Given this list of marker genes Zbtb24, Dtx1, Extl2, Tcf20, Mgat5, Pygo1 (pygopus 1, NCBI Gene Id 72135), Slfn8, Zfp93, Znrf3, Pex2 (NCBI Gene Id 52109), Agap3, Zfp24, Cyp2c55, Smyd3, Zmynd8, Cyp2b9, Rasal1, Rarg, Prdm16, Rest, Phf2, Dbh, Zfp146, Wdfy2, Tet1, Npepl1, Zfp14, Tshz3 (NCBI Gene Id 338507), Kat6b, Dpys, Ang6, Galnt4, Adap2, Acap1, Rbm4, Zup1, Scd1, S100a3, Semg1, Tk1, Zfp687, Dmd (dystrophin, muscular dystrophy), Nudt16, Rnf185, Neil2, Rpl37a, Zcwpw2, Zfp706, Usp19, Git1, Scd3, Egr4, Cyp2u1, Zfand4, Trim67, Zglp1, Tdrd1, Enpep, Suz12, Cbll1, Klf7, Rnf14, Cpe, Zkscan14, Aire, Ace, Tesl2, Kmt2b, Rbsn, Car7, Litaf, Esr1, Atf2, Tcea1, Prkce, Tnip2, Nr5a1, Zmym5, Cgrrf1, Alox8, Rtp4, Cyp2c37, Mta2 (NCBI Gene Id 23942), Zfp628, Pim1, Rnf122, Trim45, Cpn1 (NCBI Gene Id 93721), Phf7, Trim28, Prkci, Scd4, Zeb2, Ikzf3, Smyd1, Yod1, Zfp668, Rad18, Esr2, Nr3c1, Mgrn1, Kdm4b, Unc13c, Ch25h, Alox5, Trhde, Zscan21, Dpp3, Dgka, Rbm20, Hdac4, Thap4, Ethe1, Prm2, Ankmy1, Galnt3, Loxl4, Nr5a2, Gatad1, Upf1, Mre11a, Smpdl3a, Ing2, Rnf8, Zfp932, Trim66, Kmt2e, Car2, Brpf3, Adnp2, Nr2e3, Nr6a1, Sod1, Trim54, Sprtn, Ccnb1ip1, Tax1bp1, Sec23a, Rbbp6, Mib2, Shprh (SNF2 histone linker PHD RING helicase), Astl, Hephl1, Wdr59 (WD repeat domain 59), Gstm1, Gtf2e1 (general transcription factor II E, polypeptide 1 (alpha subunit)), Ebf3, Rnf13, Polr2k, Rnf215, Mid2, Trim26, Timp3, Mgat5b, Prkcz, Rnf144b, Nr1h2, Zbtb6, Shank3, Xpa, Phf11a, Cyp1b1, Hmgcl, Hic2, Ing1, Otud7a, Commd1, Cbl, Cblb, Nbr1, Pepd, Mmp17, Trim65, Fgd4, Epas1 (endothelial PAS domain protein 1), Zfat, Pglyrp1, Kcmf1, Prnd, Fthl17a, Ppm1k, Prkch, Zmym2, S100a5, Adamts1, Toe1, Dcst1, Papola, Car9, Cyp2a4, Zfp322a, Cdip1, S100a4, Arg1, Srek1ip1, Kat8, Nr3c2, Ptms, Mllt10, Flywch1, Mmp11, Zfp697, Morc2a, Cyp1a1, Nob1 (NCBI Gene Id 67619), Zfp418, Zcchc2, Dclre1a, Osr1, Hltf, Mlph, Zfp689 (NCBI Gene Id 71131), Gli3, Mmp15, Nr2e1, Agmo (NCBI Gene Id 319660), Ptch1, Polr2i, Cyp2c39, Idi1-ps1, Zfp28, Fntb, Hpd, Ppm1n, Phc3, Acp5, Gata2, Glis3 (GLIS family zinc finger 3), Zfp184, Kdm5d, Zfp536, Polr1a, Marchf8, Zfp296, Pogz, Zmiz2, Tab3, Atp2c1, Hdac6, Dtx4, Aox4, Alox12b, Irf2bp2, Car4, Car14, Zfand1, Flg2, Zfp511, Sharpin, Zswim8, Obi1, Bbox1, Zbbx, Fn1, Mgat1, Zfp1, Moxd1, Vav2, Alpi, Rnf166, Xdh, Zfp608, Siva1, Maz (NCBI Gene Id 17188), Zfp335, Anapc11, Polh, Zfp143, Cdo1, Dtna, Zfp653, Esco2, Rbak, Loxl2, Hr, Mdm4, Tiparp, Snrnp48, Zfp326, Rock2, Pnma3, Tshz1, Zfp385c, Prkd2, Zmynd15, Prdm14, Parp12, Rtl4, Polr1h, Cyp2b19, Eprs1, Zfp3, Tut7, Adcy2 (NCBI Gene Id 238696), Gpx3, Gpatch8, Zfp35, Plekhm3, Cuta, Marchf5, Ash1l, Nr4a3, Zc3h6, Zfp592, Thap11 (NCBI Gene Id 76841), Smyd5, Wrnip1, Car1, Fthl17f, Zfp488, Zscan4f, Egr2, Casz1, Tnfaip3, Car11, Fhit, Smyd4, Capn15, Rnf148, Ciapin1, Akp3, Nr2c1, Glis2, Tns2 (NCBI Gene Id 209039), Rnf43, Rnf10, Sp4, Ing4, Nr2f2, Dtx3, Vav1, Chd4, Sh3rf1, Cnot4, Vps41, Peg3, Prkn, Ide, Sirt3, Hnf4g, Phf1, Rc3h1, Unc13a, Ar, Thap1, Car3, Adnp, Zfpl1, Cxxc5, Tab2, Atrx, L3mbtl4, Dtx3l, Zfp639, Mynn, Trim10, Rnpep, Pcgf6, Rims1, Zfp451, Zscan20, Polr3b, Zbtb7b, Bmx, Fan1, Pcgf1, Pex10, Champ1, Zfp580, Rere, Timp2, Klf17, Svs3b, Cad, Baz2a, Mefv, Rnasel, Esrrg (NCBI Gene Id 26381), Hivep2, Zfp54, Brf1, Zfp654, Zfand5, Zfp518b, Coa6 (cytochrome c oxidase assembly factor 6), Chordc1, Tars1, Zc3h14, Prickle3, Svs3a, Rnf6, Zfp280d, Dgkb, Prickle1, Arap1, Cyp27a1, Lnpk, Trps1, Pias3, Cyp3a25, Rnf19a, Slx4, Dhx57, Zfp579, Rnf103 (NCBI Gene Id 232080), Cyp21a1, Nudt3, Trim43c (tripartite motif-containing 43C), F5, Zfyve19, Nos1, Chn2, Ski, Mkrn2, Rtp3, Cyp3a11, Brf2, Cyp2d26, Rorc, Zfp830, Rnf182, Cyp2c29, Sall1, Adh6b, Pglyrp3, Zfp90, Zc3h3, Cyp2s1 (cytochrome P450, family 2, subfamily s, polypeptide 1), S100a7a, Rffl, Mib1, Fthl17b, Cyp2c40, Zgpat, Zbed6, Dpyd, Trim13, Trim32, Zc3hav1, Hic1, Mmp7, Zmym3, Plod1, Lhx5, E4f1, Zfp354c, Smpd1, Qpct, Zfp750, Heph, Mnat1, Mt2, Zfp276, Calcoco1, Nup42, Fto, Ppara, Grin2b, Zbed4, Rps27a, Th, Aopep, Runx1t1, Bcl6, L3mbtl2, Matr3, Gpc1, Fus, Rtn4ip1, Siah1a, Ppp1ca, Prr3, Supt4b, Siah2, Zfand6, Sumf1, Itk, Gfi1, Zfy1, Abcc8, Zc3h13, Lnx1, Zswim5, Aplp1, Msmo1, Dhx58, Zfp330, Zfp277, Zfp821, Baz1b, Triml1, Fgd2, Wdr24, Plekhm1, Zfp128, Dnaja3, Sirt5, Rbm5, Kdm5a, Tns1, Slc4a8, Zgrf1, Trim16, Ppef1, Zfp445, Egr3, Rnft1, Trmt44, Dzank1, Mme (membrane metallo endopeptidase), Cpa3, Dnaja2 (DnaJ heat shock protein family (Hsp40) member A2), Lonrf3 (NCBI Gene Id 74365), Zfp638, Hinfp, Zfp41, Gda, Mgat2, Hdac10, Nfu1, Rspry1, Cyp4f18, Plscr3, Galnt1, Akap8l, Hba-x, Zfp292, Rxra, Prdm8, Adamts8, S100b, Calr, Kdm2b, Gcm1, B4galt1, Trim46, Adh4, Lin28a, Samhd1, Aoc3, Bcl11a, Prdm1, Sall2, Cpz, Asap3, Traf1, Nqo2, Slu7, Sec24a, Zhx2, Mbd1 (NCBI Gene Id 17190), Cyp2c23, Fezf1, Zfpm1, Xpnpep3, Cyp26c1, Rpl37, Bspry, Dgkz (diacylglycerol kinase zeta), Pglyrp2, Patz1, Zfp37, Mecom, Rnf223, Cyp4a10, Tdp2, Cyp2f2, Fthl17e, Zfp473, Zcrb1, Sec24d, Racgap1, Zfr, Zfp683, Zmat5, Aox1, Thap2, Supt4a, Mss51, Zfp800, Gyg1, Znfx1, L3mbtl1, Ighmbp2, Fgd6, Ctcf, Tut4 (terminal uridylyl transferase 4), Fthl17c, Phf21a, Marchf9, Zfp329, Qtrt2, Usp49, Cbfa2t2, Bsn, Rnf20, Rnf135, Zfpm2, Zswim4, Smap2, Aoc1, Apobec1, Agbl4, Zbtb8a, Dpep1, Zfp462, Zfhx4, Zswim7 (NCBI Gene Id 69747), Cyp2a5, Zkscan5, Agbl2, Rnf121, Sec24b, Ankzf1, Trmt1, Ang4, Rp9, Polr1b, Zcchc3, Zfp27, Zfp239 (NCBI Gene Id 22685), Ebf2, Sco2, Nr4a2, Osr2, Fgd5, Gch1, Rreb1 (NCBI Gene Id 68750), Hgs, Zfp879 (NCBI Gene Id 214779), Shh, Zfy2, Mid1, Rnf146, Cox11, Zfp287, Rnf128 (ring finger protein 128), Trp53, Zfp74, Rev3l, Zfp768, Dctd, Zfp710, Usp16, Klf5, Fa2h, Zfp12, Tssk3, Zfp346, Rnf212b, Ftmt, Fthl17d, Ogfod1, B4galt7, Trim34a, Dnmt3a, Zfp426, Lnx2, Arhgap29, Ppm1b, Lcn2, Rnf111, Def8, Sp8, Zfp775, Myt1l, Abo, Dgkg, Alox15, Sytl5, Cdadc1 (cytidine and dCMP deaminase domain containing 1), Zfp366, Trim14 (tripartite motif-containing 14), Trim56, Recql4, Rnf11, Cpa4, Cyp2c50, Zcchc18 (zinc finger, CCHC domain containing 18), Zfp646, Exd2, Ftl1, Ppef2, Rag1, Agfg2 (NCBI Gene Id 320059), Zhx1, Mmp2, Chfr, Mmp19, A430033K04Rik, Zswim3, Zfyve26, Plod2, Dnaja4, Lancl1, Sncb, Trim40, Phf19, Rnf7, Idi1 (isopentenyl-diphosphate delta isomerase), Vat1, Aicda, Or4e2, Sp9, Mul1, Zfp316, Alox12e (arachidonate lipoxygenase, epidermal), Adi1, Ube3a, Zfp280c, Zpr1, Kdm1b, Rbm10, Hamp, Agap1 (ArfGAP with GTPase domain, ankyrin repeat and PH domain 1), Cpa6, Dtnb, Asap1, Kmt2d, Mkrn3, Adamts15, Vav3 (vav 3 oncogene), U2af1, Chd5, Sntn, Zfp385b, Mmp20, Trim6, Arfgap3, Dpf1, Cdc42bpa, Trim41, Tada2a, Zfp786, Zc3hc1, Prdm4, Rnf183, Gata3, Cyp4a14, Zfp598, Haao, Zfp422, Rnf126, Trim60, Scnm1, Ikzf2, Atp7b, Prkcb, Rarb, Pias4, Gtf2h2, Prdm10, Zranb2, Smpdl3b, Zbtb7a, Trim59, Zfp513, Hrnr, Akap8, Stac, Mmp12 (NCBI Gene Id 17381), Tcea3, Agbl5, Zbtb5, Ifih1, Rnf216, Taf1b (NCBI Gene Id 78429), Zkscan3, Ece1, Birc7, Hhip (NCBI Gene Id 56864), Klf3, Cyp4v3, Zfp652, Sap30l, Bhmt1b, Prickle2, Git2, Enpp1, Rtp1, Rnf167, Vdr, Jade2, Zfp526, Zfp106, Prim1, Trim38, Irf2bp1, Cyp26a1 (NCBI Gene Id 13082), Cyp7b1, Bard1, Trit1, Zfp82, Mmp3, Trim42, Zbtb43, Zbtb46, Rbm22, Marchf3, Txnrd1, Zfp428, Arfgap1, Ebf4, Klf9, Nr4a1 (nuclear receptor subfamily 4, group A, member 1), Zik1, Polr2l (polymerase (RNA) II (DNA directed) polypeptide L), Arfgap2, Trim3, Sap30, Adprm (NCBI Gene Id 66358), Usp20, Pck1, Zranb1, Znrf4, Bhmt2, Lox, Usp45, Uimc1, Usp22, Trim36, Esrrb, Car15, Rnf25, Zic2, Rnf141, Cyp2d9, Ccs (NCBI Gene Id 12460), Scrt1, Fam20c, Rpa1, Pgr, Klf14, Zfp39, Aplp2, Cdipt, Klf10, Syvn1, Car13 (NCBI Gene Id 71934), Xpnpep1, Klf1, Birc5, Adam8, Bmi1, Rxrb, Zrsr2, Traf4, Neurl1a, U2af1l4, Ado, Trim43b (NCBI Gene Id 97529), Vat1l, Tesl1, Neurl3, Zfp770 (NCBI Gene Id 228491), Ing3, Sall4, Znrf2, Pola1, Wdfy3, Mtf2, Ing5, Mta1, Zfp827, Trip12, Mmp21, Eri2, Zfp664, G2e3, Acer3, Rph3al, Cyp11b2, Fyco1, Rnf224, Tbxas1, Sytl3, Thrb (NCBI Gene Id 21834), Ankfy1, Zfp672, Lap3, Prkd1, Trerf1, Thap12, Ada, Sod2, Sp1, Zfp91, Cyp2w1, Zfp414, Rufy4, Zfp523, Zc2hc1c, Cyp2d10, Ankmy2, Acmsd, Zcchc4, Trim30a (tripartite motif-containing 30A), Adamts2 (NCBI Gene Id 327918), Top3a, Btk, Timp4, Tut1, Trim71, Pole, Tes, Cyp2b10, Zfp704, Tet3, Pter, Sec23b, Prkcg, S100a6, Klf16, Unkl, Rnf26, Zbtb3, Lvrn, Unk, Crebbp, Rnf144a, Pitrm1, Znhit1, Ppm1a, Rnf115, Znrf1, Zcchc17, Cyp2c70, Dnmt1, Cpsf4, Helz2, Zfp110, Jmjd1c, Itgb1bp2, Smyd2, Zranb3, Jade1, Mt3, Il1a, Rc3h2, Zfp369, Ints12, Gmip, Enpp7, Ikzf4, Ovol3, Bmp1, Lims1, Glo1, Car5a, Zfp711, Fnta, Fbxo43, Zmat3, Zfp521, Ppard, Phf20l1, Cyp2r1, Trim39, Dido1, Prnp, Pcgf5, Fhl2, Zfp13, Aoc1l3, Pja1, Chn1, Rasa2, Gata5, Raf1, Npepps, Zfp551, Gfi1b, Nek4, Traf3, Agtpbp1 (ATP/GTP binding protein 1), Riox1 (ribosomal oxygenase 1), Ptgr3, Mbnl3, Rtp2, Litafd, Dzip1, Arap2, Nhlrc1, Kdm5b (lysine demethylase 5B), Nsd3, Rnf152 (NCBI Gene Id 320311), Rorb, Cdc42bpg, Msrb1, Rps29, Upb1, Tll2, Pggt1b, Zfand2a, Myt1, Zbtb48, Bhmt, Erap1, Uhrf1, Ep300, Klf15, Nr1h4 (nuclear receptor subfamily 1, group H, member 4), Ark2c, Zfp142, Fbxl19, Rnf145, Ltn1, Dpf3, Zfp64, Fbxo40, Apip, St18, Prdm13, Ppm1m, Lacc1, Abce1, Ddah1, Trip4, Cyp24a1, Plag1, Trim25, Zbtb33, Zfp667, Zfp92, Rbm4b, Lhx1, Czib, Ahcy, Mtmr4, Alkbh8, Cyp46a1, Cyp19a1, Ctcfl (CCCTC-binding factor like), Dzip3, Aebp2, Zic3, Zfyve27, Zmym4, Usp5, Adamts9, Traf5, Rnf31, Srsf7, Setmar, Asah2, Aebp1, Zfp641, Jazf1, Nr2c2, Rtl3, Polr3a, Zfp629, Gata1, Zbed3, Zfp809 (zinc finger protein 809), Fech, Cyp3a13, Zfp382, Mcm10, Tph1, Zscan12, Ogfod2, Trim50, Wrn, Ins2, Sh3rf3, Parp1, Rplp2, Zfp36l1, Rabggtb, Brpf1, Trim29, Rora, Zfp553, Pias2 (NCBI Gene Id 70728), Rabgef1, Brca1, Gzf1, Phf6, Zmynd11, Birc2, Suv39h2, Park7, Trim69, Agbl1, Setdb1, Dgkq, Zfp575, Clip1, Cyp20a1, Tyw5, Tnfsf10, Rag2, Tnks, Adh7, Rnf212, Rnf149 (ring finger protein 149), Arg2, Fhl5, Xiap, Rnf151, Alkbh2, Ppp1r10, Napepld, Rnf150, Zcchc14, Zbtb11, Marchf1, Cyp2j5, Zfp207 (zinc finger protein 207), Faap20, Fbxo5, Ksr2, Trmt1l, Deaf1, Insm1, Pck2, Zfp367, Phf14, Zcchc8, Brap, Ang2, Rph3a, Zkscan17, Lyar, Map3k1, Zfp637, Zfp30, Slx1b, Rchy1, Msl2, Znhit2, Trim21, Sf3a2, Zic1, Vps8, Jmjd6, Sc5d, Zc3h12c, Ears2, Cryz, Glis1, Xxylt1, Klf4, Cyp11a1, Foxp4, Insm2, Enpp3, Pja2 (NCBI Gene Id 224938), Cyld, Cisd1, Tchhl1, Zfp804a, Trafd1, Mbnl2, Arid2, Zfp26, Zfp609, Zscan10, Zfand2b, Zmat2, Zc3h4, Zfp593, Myrip, Xaf1, Mylip, Traf7, Snca, Dus3l, Fgd3, Nfx1, Usp3, Phyh (phytanoyl-CoA hydroxylase), Tank, Kdm7a, Zc3hav1l, Zc3h18, Aoc1l2, Rapsn, Gata4, Zbtb42, Enpp2, Zfp423, Sirt6, Baz1a, Trim47, Snai3, Cyp2a12, Trim63, Ubr5, Zfp36l3, Zfp512, Cyp4b1, Nt5e, Plekhf2, Rassf1, Hivep1, Mtpap, Pah, Ltf, Rnf130, Drp2, Kdm5c, Zfp131, P2rx7, Gtf2h3, Zxdc, Cpxm2, Aoc1l1, Sh3rf2, Polr2a (polymerase (RNA) II (DNA directed) polypeptide A), Zfp36, Ptpn1, Mbnl1, Cpd, Myo9b, Zfp865, Zfp182, Rnf157, Rpain, Rida, Foxp1, Snai2, Sp7, Wdfy1, Ehmt1, Rxrg, Nudt12, Churc1, Slfn9, Mmp14, Phf10, Lhx3, Rnf123, Dbf4, Zbtb41, Zfp691, Tyr, Mocos, Wiz, Dpf2 (double PHD fingers 2), Msrb3, Galt (NCBI Gene Id 14430), Zdhhc20, Zfp583, P4ha2, Thap3, Pam, Gli1, Cpxm1, Rnf169, Zmynd19, Yy1, Arhgef2, Zfp410, Klf11, Zfp46, Aptx, Marchf7, Zfp474, Mmp16, Zfyve16, Rmnd5a, Topors, Dtx2, Ftl2-ps (NCBI Gene Id 14337), Sf3a3, Cutc, Scd2, Qpctl, Sp6, Cyp2j6, Peg10, Suox, Dcp2, Aars2, Pcgf2, Prkca, Car8, Zc4h2, Fen1, Unc13b, Rnf32, Fxn, Bnc2, Zc3h8, Znhit6, Ptgr2, P4ha1, Zfp365, Dnmt3l, Usp39 (NCBI Gene Id 28035), Zbtb14, Ttf2, Zfp458, Pcgf3, Zc3h10, Phf20, Dytn, Dnlz, Thra, Zscan2, Cox17, Trim72, Rigi, Cdc42bpb, Nsd2, Mex3b, Smad3, Mycbp2, Zfp318, Trim58, Zfhx3, Ubr1, P2rx4, Zbtb9, Rpap2, Trim31, Zfp740, Gtsf1, Trim8, Ang5, Dusp12, Alox12, Cyp8b1, Mcm2, Sp2, Phf11d, Sncg, Rbck1, Rnpepl1, Mt1, Egr1, Dgkd, Rictor, Timm8a1 (translocase of inner mitochondrial membrane 8A1), Zfp507, Zbtb4, Zswim1, Abl2, Zfp541, Polk, Pold1, Nudt7, Wt1, Prn, Klf2, Nanos2, Pla2g15, Zfp281, Mmp9, Ehmt2 (NCBI Gene Id 52041), Zfp62, Lhx4, Trim44, Zkscan6, Fgd1, Myo9a, Pml, Mpped2, Zfp120, Dhh, Rnf24, Rnf168, Alkbh3 (NCBI Gene Id 73573), Prdm15, S100a13, Cyp4f14, Dgke, Helz, Traf2, Morc4, Egln1, Rmnd5b, Scrt2, Zswim6, Uhrf2 (ubiquitin-like, containing PHD and RING finger domains 2), Tec, Acap2, Miox, Zfp42, Cpa2, Mmp24 (matrix metallopeptidase 24), Birc3, Zfyve21, Sirt4, App, Pan3, F8, P3h2, Zbtb18, Traf6, Pde2a, Slc39a4, Zfp57, Neurl1b, Cyp4a12b, Trim17, Zfp622, Zfp518a, Tcea2, Atf7, Zbtb49, Kdm4c, Asxl3, Nr1h3, Cit (citron), Dnmt3b, Rasgrp2 (NCBI Gene Id 386467), Sqstm1, Pdzd8, Aars1, Zfp532, Dph3, Apex2, Rps27l, Rabif, Galnt2, Cygb, Sall3, Aox3, Ubr3, Klf6, Rnf181, Mta3, Lmcd1, Lig3, Polr3k, Rfwd3, Ovol1, Zcchc7, Zbtb17, Phf5a, Zmynd10, Zfp219, Irf2bpl, Ubr4, Zfp568, Klf8, Rnf112, Maea, Mmp23, Cul9, Nr1i3, Naaladl1, Rptn, Tmem163, Usp44, Ubr7, Zswim2, Cyp1a2, Tph2 (NCBI Gene Id 237554), Zfp148, Rasgrp4, Repin1, Lin28b, Uba5, Lrsam1, Aplf, Zbtb8b, Zfp385a, Prdm12, Blvra, P3h1, Zmat4, Adat2, Thap7, Brd1, Plod3, Fancl, Dyrk2, Zzz3, P2rx2, Cpm, Smap1 (NCBI Gene Id 98366), Urod, Moxd2, S100g, Zfyve1, Mex3c, Mex3d (mex3 RNA binding family member D), Rybp, Gatad2a, Ogfod3, Nsd1, Zic5, Trim43a, Prkcd, Afg3l2, Crip1, Lnpep, Rgn, Or5ar1, Adamts20, Aloxe3, Taf3, Ring1, Rnf40, Ubox5, Zfp2, Kmt2a, Nr1d1, Rnf133, Rlim, Zcchc10, Trim7, Trim11, Mtr, Zc3h15, Lonrf1, Nanos1, Mtarc2, Rims2, Rnf41, Arhgap45, Mtarc1, Zftraf1, Mmp1a, Hif1an, Fam170a, Rnf138, Rnf19b, Ftl1-ps2, Rnf220, Adh6a, Cyp2d11, Zdhhc15 (zinc finger, DHHC domain containing 15), Zfp618, Cyp2c54, Trim9, Zc3h12a, Cdkn1a, Tshz2, Herc2, Trim75, Baz2b, Zbtb1, Yy2, Cyp7a1, Cda, Prdm9, Bcl6b, Zc2hc1b, Asxl1, Nsmce2, Nr2f1, Cp, Mpi, Prdm6, Hnf4a, Mep1a, Trim68, Zfp319, Zfand3, Arih2, Cyp4x1, Mep1b, Trim33, Mdm2, Slc31a1, Fhl3, Snai1, Hba-a1, Trmt13, Cyp4a12a, Muc2, L3mbtl3, Bnc1, Neil1, Zfp36l2, Prdm5, Prmt3, Kat6a, Fth1, Vps11, Egln2 (NCBI Gene Id 97399), Rasa4 (RAS p21 protein activator 4), Nr1i2, Morc3, Adam33, Kdm3b, Ankib1, Ttc3, Elof1 (ELF1 homolog, elongation factor 1), Iscu, Me1, Asxl2, Zcchc9, Fbxl5, Zfp524, Marchf11, Gatad2b, Dgkh, Zfp354a, Zfp692, Car6, Hivep3, Prkaca, Ftdc1, Ptgis, Ash2l, Cpb2, Phf21b, Eea1, Trim24, Pias1, Zfhx2, Adamts4, Zfp746, Ranbp2, Zfp771, Meltf, Large1, Atxn7l3, Sec24c, Zxdb, Cpa1, Slc30a7, Zfp784, Ovol2, Bcl11b, Primpol, Pparg, Stac3, Hrg, Pglyrp4, Zfp354b, Zfp647, Ino80b, Zfp60, Rock1, Cyp2c38, Zfyve28, Mbtd1, Rufy2, Fdx1, Ewsr1, Kdm4a, Glul, Sp3, Ebf1, Ikbkg, mt-Co2, Pdxk, Adcy10, Cyp2e1, Nudt8, Aco2, Wbp4, Zzef1, Rnf2, Rnf17, Ang, Zbtb20, Cpa5, Znhit3, Mtmr3, Zfx, Aoc2, Amfr, Zcchc24, Zfyve9, Rabggta, Rbm26, Rnf170, Phc2, Zbtb32, Mmp25, Gata6, Rnf4, Dnpep, Plscr2 (phospholipid scramblase 2), Car12, Phc1, Phf8, Zc2hc1a, Kat5, Setdb2, Rasa3, Rnf44, Phrf1, Cyp39a1, Cyp17a1, Agfg1, Marchf4, Zc3h11a, Marchf2, Rai1, Sobp, Traip, Bfar, Zfp11, Nufip1, Pomgnt1, Arih1, Nr2f6, Rnf207, Sord, Trf, Zfp58, P4ha3, Zhx3, Trim35, Zfp661, D2hgdh, Fezf2, P3h3, Zfp59, Fbxo30, Nr1d2, Atmin, Abl1, Zcwpw1, Trim34b, Sod3, Fhl1 (NCBI Gene Id 14199), Marchf6, Nsmce1, Pex12, Alkbh1, Metap1, Impa1, Siah1b, Zfp703, Lactb2, Cblc, Rnf139, Kdm3a, Zscan4c, Slc11a2, Rasgrp1, Arhgef28, Prkcq, Mmel1, Zbtb7c, Pdzrn3, Usp51, Blm, Ikzf5, Rnf208, Agbl3, Rnf180, Kin, Zic4, Rnf225, Vps18, Rrm2, Gli2, Stac2, Trim12a, Phf23, Glra1, Egln3, Dnajc24, Utrn, Rnf5, Zfp503, P4htm, Dohh, Usp33, Mmp1b, Tbkbp1, Agap2, Inhca, Rufy1, Adh1, Aox2, Gtf2b, Zfp263, Eif2s2 (eukaryotic translation initiation factor 2 subunit 2 beta), Zfp516, Xylt2, Ubr2, Kdm2a, Apobec3, Rplp2-ps1, Itpr3, Mios, Cnbp, Trim37, Plekhf1, Timp1, Sf1 (splicing factor 1), Cyp3a16, Zc3h12d, Foxp3, Mybbp1a, Ftdc2, Cutal, Ddx41, Atp7a, Loxl3, Rnf38, Phf24, Zbtb45, Zscan4d, Isca2, Fiz1, Nup153, Rnf114, Klf13, Jade3, Usp13, Rnf213, Zfp69, Prkd3, Msrb2, Mkrn1, Cbfa2t3, Yaf2, Pikfyve, Atox1, Rnf34, Zscan26, Zbtb22, Araf, Dzip1l, Dnajc21, Akap13, Xrn2, Pclo, Zkscan1, Rps27, Zar1l, Zmat1, Morc1, Sirt2, Tet2, Rara, Tll1, Adamts5, Phf12, Rnf186, Tmem129, Enpp5, Nanos3, Esco1, Ikzf1, Cop1, Rnf125, Mmp8, Gtsf1l, Zfp260, Cyp27b1, Rnf222, Suv39h1, Foxp2, Trim2 (NCBI Gene Id 80890), Snrpc, Pld6, Rfpl4, Cyp26b1, Zfp112, Cyp51, Ddx59, Zmiz1, Mmp13, Neil3, Morc2b, Zeb1, Phf13, Car5b, Zbtb44, Zar1, Tnp2 (NCBI Gene Id 21959), Cd4, Mmp10, Polr2b, Dnaja1, Pdcd2, Trim62, Alad, Rnf214, Apoa4, Cxxc4, Plscr1, Rbm27, Rnft2, Zfp467, Kmt2c, Fbxo11, Zfp787, Rnf187, Rbx1, Gtf3a, Mtf1, Spg7, Cxxc1, Rnf227, Clpx, Lta4h, Nploc4, Grin2a, Trim23, Arhgef18, Optn, Anpep, Kat7, Adh5, Zcchc12, Ksr1, 4931406C07Rik, Trim27, Esrra, Afg3l1, Alb, Leng9, Sp5, Rassf5 (Ras association (RalGDS/AF-6) domain family member 5), Zfp574, Sytl4, Rnf217, Calb1, Klf12, Otud7b, Car10, Loxl1, Mppe1, here is a description of the gene set: Binding to a transition metal ions; a transition metal is an element whose atom has an incomplete d-subshell of extranuclear electrons, or which gives rise to a cation or cations with an incomplete d-subshell. Transition metals often have more than one valency state. Biologically relevant transition metals include vanadium, manganese, iron, copper, cobalt, nickel, molybdenum and silver. Mouse Gene Set: GOMF_TRANSITION_METAL_ION_BINDING studied in species Mus musculus